The following is a description of a gene set: from publication Chen Y, Wang X (PMID 31504780) Genes predicted to be targets of miRBase v22 microRNA mmu_miR_125a_3p in miRDB v6.0 with MirTarget v4 prediction scores > 80 (high confidence targets). Mouse Gene Set: MIR_125A_3P species: Mus musculus, and this is the list of marker genes: Ttpal, Spg7, 4930555G01Rik, Pttg1ip, Ino80, Epm2aip1, Sh2b2, Tbl1xr1, Was, Sipa1l2, Gm3696, Ptprz1, Lamp5, Nudt4 (NCBI Gene Id 71207), Col23a1, Tmco3, Map1b, Phyh, Cers5, Mab21l2, Capn7, Septin11, Timm8a1, Tmem114, Msrb2, Gkn1, Cldn12, Pakap (NCBI Gene Id 97198), Nploc4, Gpr17, Larp4, Trpm3, Adam28, Mprip, Brca1, Tspan11, Slc8a1, Thoc2, Yipf4, Ldb2, Abraxas1, E2f8, Tcerg1, Nlk, Fstl1, Sec22a, Utp14b, 1700123O20Rik, Ntan1, Mycl, Satl1, Psmd12, Ly6g5b, Slc6a17, Dkk2, Rgs7bp, Gm3411, Kat6b, Man2b2, Kdm2a, Arhgap36, Lipk, Nsg2, Prkag3, Eif6, Mex3c, Gtf2h1, Prdm5, Zfp316, Mpc2